Given this list of marker genes Ubxn11, Kidins220, Depdc1b, Cav1 (caveolin 1, caveolae protein), Vangl1 (NCBI Gene Id 229658), Ptpn13, Muc13, Fam83b, Frs2, Wdr6, Cpd, Epha2, Rnd1, Vangl2, Pik3r2, Flot2, Txnl1, Rbmx, here is a description of the gene set: electronically inferred by orthology from the curated human pathway species: Mus musculus Reactome Pathway: RND1 GTPase cycle part of: RHO GTPase cycle This event has been computationally inferred from an event that has been demonstrated in another species.<p>The inference is based on the homology mapping from PANTHER. Briefly, reactions for which all involved PhysicalEntities (in input, output and catalyst) have a mapped orthologue/paralogue (for complexes at least 75% of components must have a mapping) are inferred to the other species.